Given this list of marker genes Gas1, Aatf, Igf1, Cradd, Pink1, Fcmr, Opa1, Pcgf2, Ackr3, Fcgr2b, Ptpn1, Gpx1, Wnt5a, Rad9a, Sfrp1, Ikbkg, Bcl10, Mdm4, Vdac2, Hyou1, Pten, Casp2, Casp8, Tgfb2, Hnrnpk, Sfrp2, G2e3, Nf1, Hspb1, Tnfrsf23, Ddx3x, Cav1, Acvr1, Runx3, Pycr1, Nacc2, Cxcl12, Gsdme, Mrtfa, Ppp2r1b, Slc25a5, Gnai2, Itga6, Bclaf1, Ei24, Col2a1, Mapk7, Alox12, Daxx, Pdia3, Pdx1, Nck2, Siah1b, Fadd, Brca1, Tnfrsf4, Fem1b, Pias4, Apaf1, Il1b, Mapk8ip2, Bmyc, Trp73, Tnf, Map2k1, Bcl2, Ivns1abp, Rtkn2, Cdk11b, Dapk3, Grina, Agt, Syvn1, Il19, Selenos, Tnfsf4, Raf1, Il7, Srpx, Eif2ak3, Gclm (glutamate-cysteine ligase, modifier subunit), Mtch2, Pea15a, Adora2a, Nrg1, Clu, Gstp1, Armc10, Rpl26, Bcap31, Cdkn2d, Pmaip1, Stradb, Fbxw7, Fgb, Bak1, Ngfr, Psen1, Gfral, Il20ra, Maged1, Gata4, Septin4, Cyct, Myc, Src, Bcl2l14, Pam16, Dab2, Taf6, Ifnb1, Ell3, Vegfa, Wnt4, Inhbb, Il10, Trp53, Rnf183, Mnt, Triap1, Cth, Jak3, Mmp9, Rrm2b, Eif2a, Traf1, Snai2, Cd74, Trap1, Bcl2l10, Kdm1a, Ndufa13, Trem2, Ubqln1, Tnfsf12, Sp100, Mfn2, Erp29, Nox1, Dnaja1, Icam1, Tlr4, Inca1, Tifab, Serinc3, Prkcd, Plaur, Mpv17l, Sirt1, Ghitm, Htra2, Dbh, Plagl2 (NCBI Gene Id 99408), Skil, Sgk3, Thbs1, Ptprc, P4hb (NCBI Gene Id 18453), Madd (NCBI Gene Id 353087), Fxn, Dapk2, Phip, Mapk8, Itgav, Ing5, Bub1, Higd1a, Parp1, Mapk9, Nog, Tnfsf11, Bcl2l1, Slc35f6, Rela, Tnfrsf12a (NCBI Gene Id 98086), Bmf, Unc5b, Nfe2l2, Trp63, Slc25a31, Dedd2, Ybx3, Mapk8ip1, Meis3, Peli3, Bad, Snai1, Akt1, Eef1e1, Tpt1, Gdnf, Nrp1, Cd44, Agap2, Pik3cb, Gata1, Gstp-ps, Fgfr1, Il4, Gper1, Plscr1, Spop, Usp15, Bcl2l2, Cx3cr1, S100a8, Atad5, Prelid1, Vhl, Csf2, Ern1, Acsl5, Psmd10, Muc1, Sh3glb1, Prkn, Bax, Prodh, Zswim2, Tnfsf14, Ripk3, Cflar, Ubb, Ddit3, Rffl, Hells, Csnk2a1, Sod2, Gsk3b, Gcg, Trim39, Eya4, Bdkrb2, Eno1b, Sod1, Eya2 (NCBI Gene Id 98933), Cyld, Tnfsf10, Tmem161a, Tert, Ltb (NCBI Gene Id 16994), Tcf7l2, Mal (myelin and lymphocyte protein, T cell differentiation protein), Stk4, Hdac2, Knl1, Mmp2 (matrix metallopeptidase 2), Ptgs2, Ctnna1, Noc2l, Psme3, Lgals3, Zmynd11, Maz, Creb3, Nck1, Rb1, Ppp1ca, Rbck1, Tnfrsf22, Ppp2r1a, Msx1 (NCBI Gene Id 269644), Vnn1, Pttg1ip, Nol3, D1Pas1, Avp, Ctnnb1, Fgg, Nfatc4, Cttn, Ppif, Traf7, Fbh1, Klf4, S100a9, Epo, Fga, Lta, Itprip, Bbc3, Slc25a4, Eya1, Ret, Cd40lg, Tnfsf15, Fgf2, Creb3l1, Becn1, Pmp22, Trps1, Nr4a2, Tgfbr1, Gclc, Zfp385a, Pak5, Gsdma3, Nkx3-1, Asah2, Sh3rf1, Rrn3, G0s2, Fbxo7, Ctsh, Prdx2, Mdm2 (NCBI Gene Id 69330), Rb1cc1, Pml, Map3k7, Atf3, Map2k5, Yap1, Htt, Igbp1, Deptor, Rps3, Ndufs3, Bmp4, Traf2, Faim2, Qars1, Kdm6a, Fignl1, Ier3, Steap3, Nme5, Txndc12, Atf4, Lck, Agtr2, Eno1, Tmc8, Ccar2, Stk3, Ctsc, Pycard, Nanos3, Ltbr (NCBI Gene Id 21932), Flcn (folliculin), Itm2c, Usp47, Nherf1, Rps7, Hdac1, Fas, Ppia, Bok, Bmi1, Dab2ip, Adcy10, Marchf7, Uri1, Cx3cl1, Bag5, Mif, Mcl1, Fgf10, Tmbim6, Fis1, Pdcd7, Ankrd2, Bcl2l12, Osm, Inhba, Wnt16, Park7, Herpud1, Gnai3, Ripk1, Dnm1l, Bdnf, Siah1a (NCBI Gene Id 20437), Wfs1, Jak2, Tnfaip3, Birc6, Hmgb2, Trim32, Nono (NCBI Gene Id 99469), Bmpr1b, Scg2, Nupr1, Camk2b, Hgf, Wnt1, Pak2, Ar, Tmem14a, Faf1, Gstp3, Ptpmt1, Ddias, Bid, Styxl1, Fasl, Acaa2, Tpd52l1, Eya3, Fyn, Serpine1 (NCBI Gene Id 231790), Hspa1b, Siah2, Zfas1, Tmbim1, Lmna, Bcl2l11, Rps6kb1, Prkra, Gstp2, App, Cep63, Stx4a, Ptpn2, Ing2, Sfpq, Hif1a, Hmox1, Psen2, Fzd1 (frizzled class receptor 1), Ppef2, Parl, Wwox, Tlr6, Faiml, Fzd9, Rack1, Siglec1, Xbp1, Rnf34 (NCBI Gene Id 97276), Lrrk2, Arrb2, Faim, Hyal2, here is a description of the gene set: Mouse Gene Set: GOBP_REGULATION_OF_APOPTOTIC_SIGNALING_PATHWAY studied in species Mus musculus Any process that modulates the frequency, rate or extent of apoptotic signaling pathway.